Given this list of marker genes Gna14, Cd36, Ffar1, Plcb3, Acsl4, here is a description of the gene set: electronically inferred by orthology from the curated human pathway part of: Regulation of insulin secretion studied in species Mus musculus Reactome Pathway: Free fatty acids regulate insulin secretion This event has been computationally inferred from an event that has been demonstrated in another species.<p>The inference is based on the homology mapping from PANTHER. Briefly, reactions for which all involved PhysicalEntities (in input, output and catalyst) have a mapped orthologue/paralogue (for complexes at least 75% of components must have a mapping) are inferred to the other species.